The following is a description of a gene set: Human Gene Set: GOBP_REGULATION_OF_OVARIAN_FOLLICLE_DEVELOPMENT Any process that modulates the frequency, rate or extent of ovarian follicle development. studied in species Homo sapiens, and this is the list of marker genes: UMODL1 (NCBI Gene Id 89766), ZP3, HYAL3, RAC1, GNRH1, AMH